The following is a description of a gene set: Mouse Gene Set: GOBP_HYALURONAN_METABOLIC_PROCESS species: Mus musculus The chemical reactions and pathways involving hyaluronan, the naturally occurring anionic form of hyaluronic acid. Hyaluronan is a type of non-sulfated glycosaminoglycan composed of the repeating disaccharide unit beta(1,4)-D-glucuronic acid-beta(1,3)-N-acetyl-D-glucosamine., and this is the list of marker genes: Tgfb1, Ap2a1, Hyal6, Slc9a1, Hyal2, Has2, Hyal1, Hexb, Itih5, Tnfaip6, Hmmr, Hyal5, Fgf2, Cemip, Il15, Abcc5, Itih2, Spam1, Cd44, Has3, Stab2, Hyal4, Smpd3, Itih3, Itih4, Nfkb1, Cltc, Pdgfb, Ccnd3, Ptger4, Gusb, Hexa, Habp4, Hyal3, Lyve1, Itih1, Has1, Cemip2, Il1b, Egf